Given this list of marker genes Flrt3, Nectin1, Dcc, Lamp5, Zfyve27, Exoc4, Exoc7, Trpv2, Gap43, here is a description of the gene set: Mouse Gene Set: GOCC_GROWTH_CONE_MEMBRANE species: Mus musculus The portion of the plasma membrane surrounding a growth cone.